Given this list of marker genes TNFRSF11A, POLR3D, NPTX1, RCOR1, ZFP1, SPRY2, KRT10-AS1, HMGN5, INSIG2, NKRF, KIF9, DGKK, SHANK2, TMEM243, KDM1B, CHMP3, NRG4, DAB1, MAN1A2, DPY19L3, UBXN4, CALN1, GIMAP4, DNAJC14, LYVE1, HIP1R, SON, ENTPD7, PABIR3, LRRN3, RNF103-CHMP3, ARHGEF15, GLIS3, ZNF365, AKIRIN2, C15orf32, RBM20, PHF24, here is a description of the gene set: from publication Chen Y, Wang X (PMID 31504780) species: Homo sapiens Genes predicted to be targets of miRBase v22 microRNA hsa-miR-656-5p in miRDB v6.0 with MirTarget v4 prediction scores > 80 (high confidence targets). Human Gene Set: MIR656_5P